The following is a description of a gene set: Mouse Gene Set: HEVNER_CORTICAL_PLATE_POSTMITOTIC_NEURONS species: Mus musculus from publication Bedogni F, Hevner RF (PMID 34321999) Genes selectively expressed by postmitotic neurons in the cortical plate of embryonic day 14.5 mouse cortex., and this is the list of marker genes: St8sia3, Rusc1, Ank2, Tmem35a, Slitrk1, B3galt1, Stmn2, Prnp, Atp9a, Gabrg2, Mapt, Tubb4a, Reep1, Dusp18 (NCBI Gene Id 75219), Rtn1, Slc7a4, Zcchc18, Sanbr, Dscam, Mapk9, Cd47, Ly6h, Syn1, Nacad, Pde4d, Evl, Tmem59l, Lingo1 (leucine rich repeat and Ig domain containing 1), Pak1, Dpysl2, Acot7, Car11, Pcgf3, Zfr2, Stmn3, Necab3, Arrb1, Pclo, Tmem229b, Olfm2, Nexmif (neurite extension and migration factor), Mtmr4, Kifap3, Mast2, Rgs6, Eno2, Sez6, Tmem178b, Gabrb2 (gamma-aminobutyric acid type A receptor subunit beta 2), Syt5, Mien1, Sez6l2, Septin3, Plppr2, Nfil3, 6330403K07Rik, Mical3, 4931406C07Rik, 5031439G07Rik, Tlcd3b, Ncs1, Plxna3, Oprl1, Asxl3, Map6, Shtn1, Atp8a2, Kif3c, Smpd3, Pnck, Gnaq, Gap43, Auts2, Prkce, Chst10, Wdr17, Ank3, Gabbr1, Bsn, Mturn, Dhx57, Phactr3, Amz2, Unc13a, Ap2b1, Jph4, Hcn3, Brinp2, B4galnt1, R3hdm4, Scn3b, Madd, Nap1l2, D630045J12Rik, Stx7, Apba2, Fry, Irgq, Acsl6, Cadm3, Tspyl4, 9130024F11Rik, Xpr1, Prepl, Jakmip1, Clasp2, Ctxn1, Islr2, Tmem44, Agtpbp1, Nf2, Mapk11, Kif5a, Syngr3, Stmn4, Arpp21 (cyclic AMP-regulated phosphoprotein, 21), Gpr22, Pfkp, Pdxp, Uchl1, Nmnat2, Ndn, Lonrf2, Map4, Lrrtm1, Nudt11, Cpeb4, Ggt7, Ddx25, Gabrb3, Ppp2r5b, Brinp1, Evi5l, Scn8a, Tbc1d24, Kidins220